Given this list of marker genes Pgk1, 6330549D23Rik, Pcbp2, Sdhaf2, Irak1, Cibar1, Hspa5, Magoh, Ino80d, Ankrd10, Hsph1, Ankrd40, Ptpmt1, Stim1, Rsrc1, Rnf7, Dennd1b, Mir5132, Elf1, Ino80dos (INO80 complex subunit D, opposite strand), Zfx, Akip1, Cnot8, Gm8495, Pafah1b1, Eaf2, Dap3, Toe1, Pold1, Sohlh2, Bod1l, Six5, Mir7238, Igfals, Psmd14, Shld2, Gsk3a, Dhx30, 1700052K11Rik, Degs1, Dnajc1, B4galt4, Hormad2, Mutyh, Tlk2, Mbd5, Ficd, Atp6ap1, Glud1 (NCBI Gene Id 14661, glutamate dehydrogenase 1), Rbm8a, Wapl, Arf1, Ibtk, Thrap3, Aldh3a2, Cdv3, Fam178b, Dmxl1, Tcea2, Gm13267, Ube2i, Sec61a2, Mvb12b, Prpf38b, Smarcc1, Hat1, Psmd3, Dido1, Orc4, Hacd2, Dis3l, Ndufb2, Rela, Bnip3l, Mapk8ip3, Cpq, Fnbp4, Armh3, Acadm, Sun1 (NCBI Gene Id 77053), Mocs1, Npepl1, Hnrnph1, here is a description of the gene set: Mouse Gene Set: ZFP322A_TARGET_GENES Genes containing one or more binding sites for (Zfp322a) in their promoter regions (TSS -1000,+100 bp) as identified by GTRD version 20.06 ChIP-seq harmonization. studied in species Mus musculus from publication Yevshin I, Sharipov R, Kolmykov S, Kondrakhin Y, Kolpakov F (PMID 30445619)